The following is a description of a gene set: species: Homo sapiens Cell-cell signaling from postsynapse to presynapse, across the synaptic cleft, mediated by a lipid ligand. Human Gene Set: GOBP_RETROGRADE_TRANS_SYNAPTIC_SIGNALING_BY_LIPID, and this is the list of marker genes: DAGLA, ABHD6, CNR1, PLCB1, FABP5